The following is a description of a gene set: Mouse Gene Set: GOBP_CELLULAR_RESPONSE_TO_RAPAMYCIN studied in species Mus musculus Any process that results in a change in state or activity of a cell (in terms of movement, secretion, enzyme production, gene expression, etc.) as a result of a rapamycin stimulus., and this is the list of marker genes: Larp1 (La ribonucleoprotein 1, translational regulator), Hnf1a, Nanog, Golph3, Arpc2